Given this list of marker genes Nufip2, Morf4l2, Afap1l2, Rftn2, Zfp280d, Mtx3, Csrnp2, Kalrn, P2rx4, Mtpap, Acss3, Hnrnpul2, Ctss, Smad1, Clca4b, Tc2n, Fbxo43 (NCBI Gene Id 78803), Kat6b, Snai2, Gys1, Setbp1, Me3, Lpp, Ids, Kcnj13, Clec2d, Tada2b, Tnks, Hycc2, Nckap5, Necap1, St8sia3, Rpl39l, Cab39, Commd10, Tfdp2, Ccser1, Glce, Lyn, Ikzf5, Zmym4, Ptp4a1, Derl2, Cyb5b, Napepld, Zmym2, Nlk, Rnf34, Mex3c, Ces2g, AI837181, Naa30, Tbk1, Rcn2, Col17a1, Phc3, Afdn, Xcl1, Fam47c, Arhgap42, Atf2, Itpr2, Krt35, Ptpn9, Nfil3, Clock, Gid8, Itga4, Macir, Zmiz1, Amot, Anks1b, Slco1a6, B3galnt1, Tlcd4, Map3k1, Umad1, Tshz3, Slc24a2, C1rl, Phf12, Slc4a4, Adgrg2, Ubr1, Plag1, Wdfy3, Pld1, Map3k7, Slc24a1, Mical2, Tusc2, Thsd7a, Psme4, Dio2, Eogt, Insyn2b, Atp5mc3, Cdh10, Synj1, Src, Crebrf, Gphn, Glcci1, Gtf3c3, Mastl, Virma, Phex, Synj2, Tubgcp3, Cpox, Usp17la, Spock3, Serpinb9c, Tbpl2, Trps1, Vmn2r81, Map3k13, Ppm1d, Rgs17, Slc39a8, Sp2, Senp7 (SUMO1/sentrin specific peptidase 7), Grhl3, Megf11, Med14, Fam180a, Epc2, Mbnl2, Nedd4l, Prps2, Naa50, Trim72, Smg1, Slc8a1, Popdc3 (NCBI Gene Id 78977), Dis3, Selenot, Mef2c, Cnih3, Gpatch1, Aak1, Ric8b, Sec24d, Rapgef1 (NCBI Gene Id 352977), Bche, Gtf2a1, Il24, Lrp2bp, Csmd3, Homer1, Zfp458, Ppm1e, Slc7a14, Nap1l5, Zfp369, Rptn, Mbnl3, Zfp148, Galnt13, Hook3, Pan3, Ythdf3, Slc12a2, Cacna2d1, Klhl15, Map1b, Ptgfr, Sh3bgrl, Ppp1r1c, Mafk, Zfp69, Ston2, Kif2a, Zfp281, Kcmf1, Sptbn1, Zbed4, Pank2 (pantothenate kinase 2), Nsdhl, Sim1, Postn, Wrnip1, Cblif (NCBI Gene Id 14603), Crppa, Morf4l1, Tpp2, Lrrtm2, Mindy2, Sgk3, Prkg1, Rab10, Nr3c1, Wsb1, Glrb, Tardbp, Zfp300, Ell2, Npas4, Slc25a46, Tyrp1, Sorcs3, Hyal4, Lratd1, Plaa, Hcar2, Prkcb, Dlg5, Krt1, Sema6a, Crebzf, Kdf1, Tbcel, Prpf19, Lats2 (NCBI Gene Id 50523), Sfrp1, Pglyrp4, 1110065P20Rik, Tnpo1, A930018P22Rik, Slc38a2, Cilk1, Plekha8, Khdrbs1, Mgat4c, Hnrnpr, Sra1, Osmr, Adamts6, Trub1, Aff4, Mbnl1, Vcpip1, Adgrg3, Lix1, Dnm1l, Rgl1, Bicral, Sema5a, Kcnk10, Zfp704, Taf4b, Atf6, Tet1, Gabarapl1, Cpne3, Spice1, Cask (calcium/calmodulin dependent serine protein kinase), Slc7a11, Spopl, Pdap1, Ahcyl1, Adamts9, Kdsr, Cdo1, Slc5a10, Cp, Tpr, Caprin1, Adamts15, Plpp3, Gabrb2, Vsnl1, Egr3, Phip, Ermard, Ddx6, Fam76b, Lgi2 (leucine-rich repeat LGI family, member 2), Uba1y, Pnpla8, Fam184b, Folh1, Zmpste24, Nell2, Rgs7bp, Atg14, Upf2, B3gnt5, S1pr1, Prkag2, Dpy19l3, Gpr180, Herpud2, Lgalsl, Cops7b, Hdac9, H2bc21, Cep170, Lnx2, Chac2, Rgs5, Dcaf10, Csn2, here is a description of the gene set: from publication Chen Y, Wang X (PMID 31504780) Genes predicted to be targets of miRBase v22 microRNA mmu_miR_203_3p in miRDB v6.0 with MirTarget v4 prediction scores > 80 (high confidence targets). Mouse Gene Set: MIR_203_3P studied in species Mus musculus